The following is a description of a gene set: from publication Gaussmann A, Wenger T, Eberle I, Bursen A, Bracharz S, Herr I, Dingermann T, Marschalek R (PMID 17130830) species: Mus musculus Human Gene Set: GAUSSMANN_MLL_AF4_FUSION_TARGETS_F_DN Down-regualted genes from the set F (Fig. 5a): specific signature shared by cells expressing AF4-MLL alone and those expressing both AF4-MLL and MLL-AF4 fusion proteins. The reciprocal chromosomal translocation t(4;11) is correlated with infant, childhood, adult and therapy-related high-risk acute leukemia. Here, we investigated the biological effects of MLL.AF4, AF4.MLL or the combination of both reciprocal fusion proteins in a conditional in vitro cell culture model system. Several parameters like cell growth, cell cycling capacity, apoptotic behavior and growth transformation were investigated under physiological and stress conditions. Co-transfected cells displayed the highest resistance against apoptotic triggers, cell cycling capacity and loss-of-contact inhibition. These analyses were complemented by gene expression profiling experiments and specific gene signatures were established for each of the three cell lines. Interestingly, co-transfected cells strongly upregulate the homeobox gene Nanog. In combination with Oct4, the Nanog homeoprotein is steering maintenance of pluripotency and self-renewal in embryonic stem cells. Transcription of Nanog and other stem cell factors, like Oct4 and Bmi1, was verified in biopsy material of t(4;11) patient cells which express both reciprocal t(4;11) fusion genes. In conclusion, the presence of both reciprocal MLL fusion proteins confers biological properties known from t(4;11) leukemia, suggesting that each of the two fusion proteins contribute specific properties and, in combination, also synergistic effects to the leukemic phenotype., and this is the list of marker genes: TMEM47, LPL, SH3GL3, TSPAN12, RAET1E, CLEC5A, OPN3, CA6, MIGA1, GADD45A, FGFBP1, NNMT, TWIST2, RRAGD, CD53, SERPINB9, MYOM2, ALDH1L2 (NCBI Gene Id 160428), HTATIP2, GSTA1, AKR1B10 (NCBI Gene Id 9405), NAP1L2, ERO1A, SERPINB2, GSTA2, GLCE, LHFPL2, AMPD3 (adenosine monophosphate deaminase 3), ABCB8, CTH, ATF5, TFPI, AGAP1, SYCP3, VEGFC, GHITM